Given this list of marker genes APAF1, PIDD1, CASP6, CASP2, TP73, TP63, CASP10, CRADD, NLRC4, ATM, TP53, CASP1, here is a description of the gene set: TP53 (p53) transcriptionally regulates cytosolic caspase activators, such as APAF1, PIDD1, and NLRC4, and caspases themselves, such as CASP1, CASP6 and CASP10. These caspases and their activators are involved either in the intrinsic apoptosis pathway or in the extrinsic apoptosis pathway triggerred by death receptors or the inflammation-related cell death pyroptosis. Reactome Pathway: TP53 Regulates Transcription of Caspase Activators and Caspases studied in species Homo sapiens part of: TP53 Regulates Transcription of Cell Death Genes